The following is a description of a gene set: electronically inferred by orthology from the curated human pathway Reactome Pathway: Regulation of mRNA stability by proteins that bind AU-rich elements part of: Metabolism of RNA species: Mus musculus This event has been computationally inferred from an event that has been demonstrated in another species.<p>The inference is based on the homology mapping from PANTHER. Briefly, reactions for which all involved PhysicalEntities (in input, output and catalyst) have a mapped orthologue/paralogue (for complexes at least 75% of components must have a mapping) are inferred to the other species., and this is the list of marker genes: Pabpc1, Psmc6, Psmd1, Psmd6, Psmc4, Psmd12, Psmb4, Psmb7, Psmd7, Psma3, Psma1, Zfp36, Ubb, Prkca, Psma4, Xpo1, Psmb6, Psma6, Psmc1, Psmb5, Dcp1a, Psma5, Psma7, Psmd13, Tnfsf13, Psma2, Hspb1, Psmc3, Rps27a, Dcp2, Psmc5, Psmc2